The following is a description of a gene set: The lipid bilayer surrounding a postsynaptic endosome. species: Homo sapiens Human Gene Set: GOCC_POSTSYNAPTIC_ENDOSOME_MEMBRANE, and this is the list of marker genes: AKAP5, RAB11FIP3, ZDHHC2, MKLN1, TFRC, GRIPAP1, ABHD17A, ABHD17B, ANP32E